The following is a description of a gene set: Each fraction of mouse hematopoietic cells was purified by cell sorting from bone marrow of 8-week-old C57BL/6 mice, and its gene expression was analyzed. Human Gene Set: GSE27786_CD8_TCELL_VS_ERYTHROBLAST_DN from publication Konuma T, Nakamura S, Miyagi S, Negishi M, Chiba T, Oguro H, Yuan J, Mochizuki-Kashio M, Ichikawa H, Miyoshi H, Vidal M, Iwama A (PMID 21540074) Genes down-regulated in comparison of CD8 T cells versus erythroblasts. species: Homo sapiens, and this is the list of marker genes: ANKRD54, USP25, ALB, CARS1, UBXN2A, HSF5, TBCCD1, CPXM1, MPZL2, SPIDR, CCN6, CTH, SMR3A, ELF5, AGMAT, NRG3, TTC16, SPINK4, TTLL9, KRTAP3-1, IRS2, LSM12, ARHGAP28, CCDC120, ZFR2, HTR2B (NCBI Gene Id 3357), LMLN, C6orf132, TFF3, CREG1, FDFT1, MRO, FZD10, PEF1, MAOA, AXDND1, CECR2, COL5A3, MACIR, ZDHHC14, MGAM, CENPQ, ADORA3, MYOF, FAM169A, THAP1, MPP4, MYCBP, GAL3ST4, RNF39, SGK3, TDRD7, TBC1D31 (NCBI Gene Id 93594), CYP4F2, CXCL14, HECW1, STRADB, ISCA2, MYEF2, PPP1R26, TIMM50, TMEM132C, HOXA13, FUT2, ACADSB, GATM, KBTBD7, OC90, RSAD2, ANO3, LRRC38, PITHD1, MTR, HP, GTF2A1, TSKU, PNMA3, DHFR, CLPTM1, KLF17, POMT2, AGFG2, FZD4, MUC4, AMMECR1, ZNF786, TCAF1, UBE2E2, EN2, CHIA, ASB6, PML, SLK, ELL3, COL2A1, BBS7, NRAP, KPNA2, DCAF10, FGF7, HSD17B2, FAM83F, TRPA1, PRKCG, AFG3L2, IL36A, R3HCC1L, FTMT, YAP1, PLA1A, MMP19, PPP1R3C, PIK3R3, FBXW10, FBXL7, GET4, PRMT8, IFIH1, DNAJA4, LOXL3, NOXO1, SYNPO2, AK5, APIP, ITIH2, ASAH2, PDE6D, ADIPOR1, TMEM125 (transmembrane protein 125), AGO4, METTL27, SPACA4, SLC30A9, PYCR2, SPATA17, TJAP1, NECTIN3, CPEB4, MESP2, IGFBP6, ACTRT1, ALDH1L1 (NCBI Gene Id 10840), SLAMF9, NAV3, DGCR8, DPF1, KRT8, NDE1, ASF1A, CELF3, PPP1R1A, HMG20B, USP21, RTL8C, NXPH3, CTTNBP2 (cortactin binding protein 2), FOXL1, MFAP4, RCVRN, SUPV3L1, EPN2, CHRD, IPMK, NDC80, CEP83, PRKG1, ACTL9, CHAD, MARCHF10, SEZ6L, OOEP, SPAM1, GAS1, PLPP4, OTP, CDCA5, SLC13A5, PARD3, B3GNT3, TNFSF4, TNN, FXYD2, RABGGTB, CDH26, USP6NL, TMEM183A, PTCRA, LY6D, JPH4, KISS1R, RFC1, FEZF1, PCDHB7, ICAM5, PALB2, DNM1, GPIHBP1, RHBDL3, DCAF12, GSPT2